Given this list of marker genes GFM2, SCN9A, FGF13, PLA2G6, SLC16A2, SPG11, ORAI1, HTT (NCBI Gene Id 3064), TPM3, COL9A1, PIGT, ADGRG1, CYP7B1, DPM1, NCF1, APC2, CD247, ATL1, MYL2, VPS37D, C19orf12, PI4KA, SLC4A10, ABCD1, LIMK1, NT5C2, COL9A3, STUB1, ADSS1, SYT2, RYR1, BUD23, COG8, NOG, TCEAL1, ATP6AP2, PSAT1, POU3F4, COL6A1, TIMM8A, COL10A1, HNRNPA2B1, NIPA1, LGI4, NFU1, IL2RA, DNMT3A, EIF4H, ESCO2, SAMD9L, KPNA3, MMP2, ANKRD55, RAB18, AARS1, IL2RB, SPAST, BPTF, TBL2, ERGIC1, FKBP6, FIG4, ERLIN1, GCSH, PSMD12, COL25A1, GDF5, TMEM270, GTF2IRD2, TPM2, DNAJC30, SLC1A4, NSD1, RTTN, VDR, COL6A3, TNNT1, MAP3K20, P4HTM, SMG9, SV2A, KIF1C, EXT2, GTF2I, CCDC88C, KIF1A, COL9A2, KLC2, NTRK1, ELN, GABRG2, SYNE1, SCO2, PIEZO1, GBA2, LMNA, ANGPT2, PYCR2, TOR1AIP1, OCA2, REEP1, CAPN3, SPTBN2, ADAMTS15, ADGRV1, UBE3A, SLC52A3, MFN2, BAZ1B, CD40LG, RETREG1, SCN1B, UBA1, STAT4, PTPN2, DYRK1A, ZMPSTE24 (zinc metallopeptidase STE24), GALC, LIFR, WNK1, CARS1, ALAD, RAB3GAP2, VAC14, GABRD, RFC2, SLC39A14, MARS1, ITGA7, GLI3, VCP, DYM (NCBI Gene Id 54808), CLCN5, COMP, DDR2, ACTA1, PRRT2, UCHL1, SCYL2, SCN1A, PTPN22, GJC2, CYP27A1, CYP2R1, IDH1, SOD1, CHMP1A, ANO5, CYP27B1, COL12A1, FA2H, HACD1, RPL10, SPART, COL6A2 (NCBI Gene Id 1292), HCN1, NFATC2, RTN2, FLT4, NDUFS8, AHDC1, KIF5A (kinesin family member 5A), MAP3K7, MAN2B1, SPTBN4, SELENOI, NEB, FLNA, SVIL, PNPT1, C18orf32, CLIP2, SGCA, MAFB, DAG1, PEX16, VARS1, STX1A, ERLIN2, PSAP, HNRNPH1, EXT1, SCN2A, ATP5F1D, KLHL9, METTL27, SELENON, ANO10, STX1B, GTF2IRD1, FKBP10, COQ4, NONO, SLC34A3, CAPN1, here is a description of the gene set: species: Homo sapiens Human Gene Set: HP_ABNORMALITY_OF_THE_ANKLE Abnormality of the ankle An anomaly of the joint that connects the foot with the leg.